The following is a description of a gene set: species: Mus musculus Mouse genes annotated to increased skin tumor incidence (MP:0010300) retrieved from the Mouse Genome Informatics database via MouseMine from publication Motenko H, Neuhauser SB, O'Keefe M, Richardson JE (PMID 26092688) Mouse Gene Set: MP_INCREASED_SKIN_TUMOR_INCIDENCE, and this is the list of marker genes: Cebpa, Braf, Lef1, Apc, Msh2, Cdkn1a, Pold1, Ctnnd1, Smad4, Brca1, Ppard, Ptch1, Kras, Pten, Rnf8, Odc1, Chuk, Trp53, Nqo1, Msh6, Eaf2, Tnk1, Snai1, Nqo2, Tom1l2, Ercc2, Hgf, Mlh1, Kit, Ndrg2, Plcd1, Polh, Tmem207, Terf2 (telomeric repeat binding factor 2), Bap1